Given this list of marker genes Rab11fip3, Bok, Aftph, Vps13b, Arfip1 (ADP-ribosylation factor interacting protein 1), Llgl1, St3gal1, Caln1, Cracr2a, Rab11a, Baiap3 (NCBI Gene Id 545192, BAI1-associated protein 3), Marchf1, Scamp2, Ap1m1, Atp2c2, Tmem165, Mmp24, Nsg1, Slc9a8, Bpnt2, Cd2ap (NCBI Gene Id 98065), Slc30a6, Scamp1, Scamp5, Ndst1, Rab31, Clba1 (clathrin binding box of aftiphilin containing 1), Scamp3, Lgr5, Fut9, Pick1, Pld4, Ap1g1, Tepsin, Ap1s2, Fcmr, Stx6, Ap1b1, Arfip2, Scamp4, Atp9a, Atp7a, Ap1s1, Atp7b, Tmem79, Myo1b, Kif13a, Cabp7, Clip3, Asap1, Ap1s3, Gnas, Nsg2, Ap1m2, Slc30a5, here is a description of the gene set: Mouse Gene Set: GOCC_TRANS_GOLGI_NETWORK_MEMBRANE The lipid bilayer surrounding any of the compartments that make up the trans-Golgi network. species: Mus musculus